Given this list of marker genes C2cd2l, Rnf41, Stim1, Atl2, Arv1, Kpnb1, Parp16, Stimate, Rab3gap1, Arl6ip1, Reep2, Reep3, Parp8, Reep1, Rab10, Reep4, Atl1, Lnpk, Rtn4, Osbpl8, Emd, Tmem201, Zfyve27, Reep5, Spast, Rab18, Parp6, Retreg3, Atl3, Asph, here is a description of the gene set: A subcompartment of the endoplasmic reticulum consisting of tubules having membranes with high curvature in cross-section. Mouse Gene Set: GOCC_ENDOPLASMIC_RETICULUM_TUBULAR_NETWORK studied in species Mus musculus